The following is a description of a gene set: studied in species Homo sapiens Pulmonary venous hypertension An abnormal increase in pressure in the pulmonary veins, usually as a result of left atrial hypertension. Human Gene Set: HP_PULMONARY_VENOUS_HYPERTENSION, and this is the list of marker genes: MYPN, KCNN4, PIEZO1 (NCBI Gene Id 9780), KIF20A, SLC4A1, FLNC, SLC37A4, TNNI3, TNNT2